Given this list of marker genes Bod1, Wdr5b, Ash2l, Setd1a, Rbbp5, Dpy30, Bod1l, Setd1b, Wdr82, Cxxc1, Hcfc1, Hcfc2, Dydc1, Wdr5, here is a description of the gene set: A conserved protein complex that catalyzes methylation of histone H3. In Saccharomyces the complex contains Shg1p, Sdc1p, Swd1p, Swd2p, Swd3p, Spp1p, Bre2p, and the trithorax-related Set1p; in mammals it contains the catalytic subunit (SETD1A or SETD1B), WDR5, WDR82, RBBP5, ASH2L/ASH2, CXXC1/CFP1, HCFC1 and DPY30. studied in species Mus musculus Mouse Gene Set: GOCC_SET1C_COMPASS_COMPLEX